The following is a description of a gene set: Intestinal hypoplasia Developmental hypoplasia of the intestine. Human Gene Set: HP_INTESTINAL_HYPOPLASIA studied in species Homo sapiens, and this is the list of marker genes: AP1S1 (NCBI Gene Id 574017), RAPSN, NUP88, GUCY2C, MAGEL2 (NCBI Gene Id 54551), ZMPSTE24, TUBA1A, SOX10, ACTG2, CLMP, MYH11, LMOD1, MYOD1, GATA6, MUSK, DOK7, LMNA, MYLK, KIF21A, FLNA, SLC18A3